The following is a description of a gene set: Human Gene Set: GSE2770_UNTREATED_VS_TGFB_AND_IL4_TREATED_ACT_CD4_TCELL_48H_UP from publication Lund R, Aittokallio T, Nevalainen O, Lahesmaa R (PMID 14607935) Genes up-regulated in CD4 T cells: untreated (0h) versus activated by anti-CD3 and anti-CD28 and then stimulated by TGFB1 and IL4 (48h). studied in species Homo sapiens Th1 and Th2 cells arise from a common precursor cell in response to triggering through the TCR and cytokine receptors for IL-12 or IL-4. This leads to activation of complex signaling pathways, which are not known in detail. Disturbances in the balance between type 1 and type 2 responses can lead to certain immune-mediated diseases. Thus, it is important to understand how Th1 and Th2 cells are generated. To clarify the mechanisms as to how IL-12 and IL-4 induce Th1 and Th2 differentiation and how TGF-beta can inhibit this process, we have used oligonucleotide arrays to examine the early polarization of Th1 and Th2 cells in the presence and absence of TGF-beta after 0, 2, 6 and 48 hours of polarization., and this is the list of marker genes: SHISA6, SSTR4, PPP1R11, PDS5A, MSS51, RPL10L, PTPRQ, RNF222, STAP1, NALF2, ZDHHC19 (zinc finger DHHC-type palmitoyltransferase 19), PDIA3, PTGS2, PATE2, RNF19B, TYR, PPP1R16B, RAB5C, RUNX3, P2RY12, UBXN7, PI4K2B (phosphatidylinositol 4-kinase type 2 beta), TRIM69, VWF, SSBP1, UBQLN4, PPP2R2A (protein phosphatase 2 regulatory subunit Balpha), PTPN4, TDRD7, WDR44, PPP2R5E, XRN2, ZYX, UBC, PLEKHG1, SLC6A14, RPL23A, SEC22A, PKP1, PIGS, TOLLIP, TTYH3, RBMS1, SLC16A4, TCIRG1, TEKT3, TDRD6, PTGFR, RAB10, UMODL1, SNAP91, RUSC2, SERPINA7, PFN1, UCHL3, PXT1, DISP3, TNP1, PRPH, STRADA, SLC50A1, PRSS37, VPREB1, PRR11, PLCE1, PHF6, POU2AF1, PRDM1, TSPAN8, PSMC3IP, TAAR6, ZFYVE26, TRIM21, SEPTIN7, SEC14L5, PLA2G2E, PNMA3, TAAR3P, TNFRSF21, TMEM37, PRAM1, ZBTB20, PLA2G12A, FAM156A, SH2D6, WBP4, SI, RIMKLB, PRKD1, RNASEH2B, TRAPPC2L, SH3BGRL (NCBI Gene Id 96022), TMPRSS11D, P2RY13, PRG4, PHOX2B, USP53, XIST, USP16, RDH8, SEC63, RPL36A, NECTIN3, SLC22A14, RLBP1, PLA2R1, SCRT2, S100A9 (S100 calcium binding protein A9), RASA4, SNX3, TOP1, SCN9A, PRAF2, OVOL2, XYLT1, PPP1R9A, ZSCAN2, SNAP25, STAT2, UNC5D, SCN10A, SLC16A8, TRPC5, ATP23, TENT4A, RBM47, TEX13A, TMEM132B, SNRPB2, TMEM168 (NCBI Gene Id 64418), RNF144A, PLPP7, SCARF2, TBK1, ZAP70, PPA2, VWA5B1, RASIP1, STRN3, SERPINA5, TSSK1B, MSRB1, SAMD3, SERPINF1, TMEM54, TAAR1, PMFBP1, POLR3C, SNIP1, TCERG1, ST6GALNAC5, PLCB1, RAB13, PTPRU